The following is a description of a gene set: Mouse genes annotated to increased liver adenoma incidence (MP:0003324) retrieved from the Mouse Genome Informatics database via MouseMine from publication Motenko H, Neuhauser SB, O'Keefe M, Richardson JE (PMID 26092688) Mouse Gene Set: MP_INCREASED_LIVER_ADENOMA_INCIDENCE species: Mus musculus, and this is the list of marker genes: Ccndbp1, Rad50, Nr1h4, Ccnd1, Fah (NCBI Gene Id 14085), Plau, Myc, Bhmt, Rassf1, Pms2, Trim24, Nfe2l1, Nbn, Eif4e, Stk11, Pex1, G6pc1, Sav1, Entpd5, Msh2, Cbx7, Bhlha15, Xpa, Ahr, Pten, Ptpn11